The following is a description of a gene set: studied in species Homo sapiens Any process that modulates the frequency, rate or extent of T-helper 2 cell differentiation. Human Gene Set: GOBP_REGULATION_OF_T_HELPER_2_CELL_DIFFERENTIATION, and this is the list of marker genes: TNFSF4, HLX, IL18, IL4R, SOCS5, ANXA1, CD86, NLRP3, BCL6, PRKCZ, RARA, ASCL2